The following is a description of a gene set: species: Homo sapiens Human Gene Set: GOBP_COP9_SIGNALOSOME_ASSEMBLY The aggregation, arrangement and bonding together of a set of components to form a COP9 signalosome., and this is the list of marker genes: COPS7B, COPS7A (NCBI Gene Id 50813), WNT3A, TESPA1, COPS8